Given this list of marker genes INTS13, PLK2, SS18, ARMC8, ZNF736, LYSMD3, SCN9A, FOXO3, CDKN2AIP, BBS5, GTF2I, SH3TC2, RCN1, DNAH5, NR3C1, DMXL2, RUFY1, SESN1, STX5, NOXRED1, CLDN18, MDGA2 (NCBI Gene Id 161357), SGIP1 (NCBI Gene Id 84251, SH3GL interacting endocytic adaptor 1), ASAP1, ZNF395, AUTS2, LNX1, PCNX1, SLC38A2, R3HDM1, USP34, PPP2R5E, GCNT1, DR1, HECW2, MPDZ, KDM5B, PRAMEF19, ZEB2, GIMAP1, STRIP2, DYRK1A, SLC35E1, ZBTB47, GLS, UBE2F, EDA, PRAMEF18, NFATC3, TAB3, SCN2A, RPS6KB1, B3GNT5, ZFR, TMPO (thymopoietin), ACTR1A, HECTD2, ETV1, TM2D3, C2orf68, ALKBH5, EIF4E, IL1R1, ILF3, NRG2, ZNF507, HIPK3, PPP1R12A, TOR1AIP2, CALU, DBN1, KRTAP4-6, SPATA1, BCLAF3, SCN3A, TENT5A (NCBI Gene Id 55603), ATRNL1, PLXNA2, CPNE4, MGMT, SERTAD4, ENTPD1, LRRC40, DISC1, SFMBT1, MSR1, YIPF4, CAMTA1, RNF8, SEC62, ZC3H12C, RANBP9, WDFY3, PTPN13, BRWD3, EFNA3, LAMP2, RAP2C, SLC36A1, MTMR6, PRRC1, EXOSC7, MED13, TMEM117, RFC5, CEP41, ZBTB43, UBE2Q2, FGF7, ERLEC1, COQ5, WDR41, ZNF248, LIN28B, TMEM79, LZTFL1, RPRD1B, SYNPO2, CASK, PASK, CCDC50, here is a description of the gene set: Genes predicted to be targets of miRBase v22 microRNA hsa-miR-1537-5p in miRDB v6.0 with MirTarget v4 prediction scores > 80 (high confidence targets). from publication Chen Y, Wang X (PMID 31504780) Human Gene Set: MIR1537_5P species: Homo sapiens